Given this list of marker genes FAF1, EXOC6B, EXT1, ERBB4, SSH2, GBE1, CSGALNACT1, MAP4K3, NR3C2, COBLL1, CCDC178, ARL15, ESRRG, FER, MACROD2, GLS (NCBI Gene Id 51679), PCDH7, STARD13 (StAR related lipid transfer domain containing 13), TRAPPC9, EFNA5, AUH, MAML2, RABGAP1L, ARB2A, ZFAND3, CD2AP, COL4A3, MEF2A, GPHN, SPIDR, XIST, EPB41L3, SMYD3, SETBP1, EIF4G3, NFE2L2, NFAT5, LRP1B, PIK3C2G, GRIP1, KIAA1958, PKHD1, KAZN, NLK, ADAMTS9, SBF2, BTBD9, ADAM10, PTGER3, SLC8A1 (NCBI Gene Id 6546), KANSL1L, FNDC3B, COMMD10, GLIS3, APBB2, ITGA2, PTPN13, SNTG1, RORA, ATP1B1, DANT2, IMMP2L, PTH2R, CAMKMT, PPP1R9A, SLIT2, PCCA, SCAPER, NAALADL2, SH3RF1, BCAS3, RALGAPA1, TRPM3, RNPC3 (NCBI Gene Id 55599), MAN1A1, KCNIP4, AHI1 (NCBI Gene Id 54806), CADPS2, MPPED2 (NCBI Gene Id 744), AGBL4, RBPMS, YAP1, FRAS1, SIK3, LCOR, CA12, WNK1, GULP1, SHROOM3, FHIT, MID1, SCN2A, PRKCA, GPC5, TRHDE, NEBL, RASAL2, PPFIBP1, GAREM1, ANK3, DEFB1, AAK1, SLC16A7, MAPK8, TMTC2, JPX (JPX transcript, XIST activator), PRKG1, TANC2, DCDC2, MITF, BICC1, PPARGC1A, ITPR1, DACH1, RHOBTB3, GNAQ, LIMCH1, TEX41, LRBA, KCNJ16, MED13L, MECOM (NCBI Gene Id 4197), BABAM2, ADGRL2, KLF12, TOX3, MLLT3, RALYL, OSBPL3, TOX, ZNF704, CCDC198, KITLG, FBXL17, DPY19L2, WWTR1, TMEM117, SCMH1, RAD51B, ADK, DLG1, WSB1, LAMB1 (NCBI Gene Id 3912), BMPR1B, HDAC8, FHOD3, ATXN1, PDE4D, HSD11B2, USP25, ADAMTS9-AS2, VAV3, ARHGAP6 (NCBI Gene Id 395), PCDH9, CDK6, LRMDA, SPIRE1, ARID5B, TCF12, LINC01099, CCSER1, MAPK10, LGR4, DYNC2H1, ITGAV, BRAF, FGF13, CALB1, MYO1B, FNDC3A, KMT2C, here is a description of the gene set: from publication Lake BB, Chen S, Hoshi M, Plongthongkum N, Salamon D, Knoten A, Vijayan A, Venkatesh R, Kim EH, Gao D, Gaut J, Zhang K, Jain S (PMID 31249312) Human Gene Set: LAKE_ADULT_KIDNEY_C15_CONNECTING_TUBULE studied in species Homo sapiens